Given this list of marker genes CACHD1, ACVR1C, SCEL, GNPAT, SMIM20, FAM20B, PLGLB2, ZNF138, PPP4R2 (NCBI Gene Id 56340), CPOX, PPM1E, TRAPPC10, CHURC1, DIO1, POGK, PLPPR1, PRKAR2B, TRDMT1, HAO1, CDR2, FOXP2, BIN1, NBR1, MACROH2A1, PLGLB1, ATP8A1, ELL2, RBL2, PCDH7, KLRC2, SMAD5, IL17RD, SLC10A2, PA2G4, C5orf24, PDS5B, POU2F1, SESN3, SFSWAP, SRSF2, VAPB, OXR1, SEMA5A, PUM2, ZDHHC20, RAB8B, MYCN, TNKS, N4BP2, PCDH17, LIPA, VCAN, PGAP1, STXBP5, RIF1, CAMTA1, QKI, SHTN1, RNF138, IFNG, SREK1, VAMP4, SRSF10, PALM2AKAP2, IPO7, MYCBP2, AAK1, LACC1, ZNRF3, TBC1D4, KCNQ5, UBE4A, HERC4, KIAA1549L, ZIC5, SLC38A2, DNAJB9, EPHA2, SAMD12, PICALM, RBMS3, RC3H1, KCNMA1, ZNF652, SPCS3, HOXC4, NCOA5, RIMKLB, VGLL3, GAPT, SDC2, STON2, ZSCAN16, IMPG1, NIPA2, OTUD6B, ST13, ATXN3, RAB40B, POGZ, USP10, MAGI3, AKT3, COL8A1, NAP1L3, PRDM10, ALG1 (NCBI Gene Id 56052), NFASC, CNIH1, HMBOX1, MCTP2, FAXC, PANK1, PSMC2, CCNC, LSM8, NDST3, GPR34, CTLA4, PRC1, LPCAT2, ERBB4 (NCBI Gene Id 2066), TM4SF18, MYCT1, MACROH2A2, SCNN1G, MMP8, GALNT13, UBE2K, NPY1R, CTNNA3, SMAD6, B3GNT5, FBXO48 (F-box protein 48), LPL, PCDH10, ARK2N, KLF12, ANKRD44, NKAIN3, PDCD6IP, ZFAND6, KIF5B, PHIP, BRD1, HOXA13, ICE2, OGFRL1, SS18, SGCD, STK17A, FFAR4, RAB4A, LRRFIP1, TFB1M, ZNF512, ZEB2, NECTIN3, YAF2, DYNLT5, KRT6C, SQLE, EBAG9, SSMEM1, YWHAQ, SMCHD1, CLOCK, MFAP3L, NR3C1, ZC3H6, ADAMTS6, RAB11FIP4, BMP2K, FUBP1, SGMS1, CALM1, PAN3 (poly(A) specific ribonuclease subunit PAN3), CPEB3, CYP7B1, LBH (LBH regulator of WNT signaling pathway), ZNF704 (NCBI Gene Id 84737), FEM1B, ESM1, PTBP3, RMND5A, PAPOLG, SLC18A2, TFRC, L2HGDH, LPGAT1, ZBTB41, CCDC186, PKIA, IRS1, PERP, CHIC1, CNOT4, HTR7 (NCBI Gene Id 3363), NIPA1, GUCY1A2, AGPAT5, PTPRB, VIT, DICER1, TOR1AIP2, YBX3, RFTN1, IPPK, A1CF, GREM2, DENND1B, RCAN2, TMF1, TOM1L1, MAGEB3, ITK, ING2, G2E3, TMEM135 (transmembrane protein 135), CCDC82, MOB1B (NCBI Gene Id 92597), TRIP11, SLITRK2, RHOQ, MOB1A, EVA1A (eva-1 homolog A, regulator of programmed cell death), PTPN4, NKX2-1, ACSL6, AMBRA1, GRIN2A, RNASE4, EBF2, UBA6, CAB39, ISCA1, TIA1, CNGB1, SNTB2, CDK2 (cyclin dependent kinase 2), LIN9, GABRA4, SRD5A3, GXYLT1, CHPF2 (chondroitin polymerizing factor 2), CLHC1, SLC16A7, TTC7B, MFSD4B, ELAPOR2, INSIG1, PAFAH1B1, EEIG2, MYRIP, ABCE1, RPAP2, DAAM1, DGKE, CABLES1, PDIK1L, ONECUT2, RPGRIP1L, NDUFS1, RAB27B, ATG14, SORCS3, BMPR2, RBM11, RAPH1, ERICH1, TFDP2, CLEC2A, TRPS1, DSTN, HOOK3, SLC4A4, TGFBR1, DCUN1D4, PLG, TMEM229A (NCBI Gene Id 730975), ADSS1, SKIL, ZNF75D, MLLT3, KNDC1, CCDC47, BTBD10, ENOPH1, GNAI1, PDS5A, SCARA3, PKDCC, OMA1, GNG2, JADE3, AQP11, ATP1B4, IQGAP2, EIF4B, PHF23, PRSS8, SIX4, C8orf34 (chromosome 8 open reading frame 34), LRATD1, IKZF2, CDC14A, ZNF597, RRN3, ANKRD46, PDE1A, CREB1, GPCPD1 (NCBI Gene Id 56261), PNISR, PRDM1, SPOPL, CLDN16, TEAD1, PTGFR, FUCA1, FGD6, FANCF, EML4, KCNQ3, HEATR1, NTRK2, UBR7, ZMAT1, ZNF81, EFEMP1, SLC12A2, WARS2, SOX6, GABPA (GA binding protein transcription factor subunit alpha), ADRA1A, ZNF274, DIAPH3, ZBTB33, SLC5A12, SSR1, AMD1, HNRNPR, ZKSCAN1, RBPMS2, CHD9, FUT9 (fucosyltransferase 9), ZDHHC21, OSBPL8, IGF1, RPS6KB1, IPP, CACNB4, TMOD2, SAXO1, SRSF12, DNAJC27 (NCBI Gene Id 51277), LIMS1, TLCD4, LMO4, SLC1A3, ATG2B, SLC35F5, OSGIN2, TRMT12, BOD1L2, RLIM, TMEM106B, LARP4B, ATL3, RAB33B, USP14, SYT4, AMZ1, GUCY1A1, FRMPD4, MMAA, BMP7, PDE12, GEMIN8, RIOK3, NEUROG1, CLDN8, THAP2, ARL3 (NCBI Gene Id 403), ZNF326, FRK, TBL2, PCMTD1, CCN4, TRMT5, CDK6, ARHGAP29, SPATA6, NCAM1 (neural cell adhesion molecule 1), KCNA4, SNX2, TNPO1 (NCBI Gene Id 3842), RPAP3, SAXO2, FAM117B, CISD2, LGALSL, TRIM2, GRAMD1C, TMEM33, LNPK, ZBTB39, C1orf43, SLC6A4, PIK3R4, BICC1, AKAP12, UBE2W, GPM6B, CREM, EXOC5, ARMC3 (NCBI Gene Id 219681), PRKCB, LARP4, FKBP1A, PSD3, RAB11A, RAB11FIP2, TASOR, MYOZ1, ZMAT3, APBB2, ARF4, TBCA, ATOSA, FAM171B, FAT3 (NCBI Gene Id 440062), SGIP1, ARID4B, CST8, LAMTOR3, PTPN21, BRDT, TENM4, PPP1R9A, MAP3K2, CENPC, CNTN4, TMTC4, DNAJA4, CSRNP3, PRKAB2, ARFGEF2, CNOT6, RSBN1, PRH2, COBLL1, C21orf91, GPATCH2L, CLTC (clathrin heavy chain), TMEM158, RERE, KIAA0040, CA5B, EFNA5, SCAI, CDCP1, CALD1, PHLDA1, MBNL3, CAST, KPNA4, HDAC9 (histone deacetylase 9), ADGRG6, FAM120A, ATP6V1B2, MCFD2, ATE1, MAB21L3, ARHGAP11A, NUS1, PLCXD3, ZNRF2, TRHR (NCBI Gene Id 7201), DOK6, PELATON, AMER2, CHMP2B, NAV2, ALDH1A2, IGF2BP3, AKAP11, KRT6A, SGPP1, NEXMIF, DCUN1D5, PGM2L1, RBM19, ARL4A, ZNF518B, LRATD2, FLACC1, MEOX1, OR11A1, RBBP8, TMTC1 (NCBI Gene Id 83857), KLHL15, BCAT1, SLC36A4, TBP, here is a description of the gene set: Human Gene Set: MIR1250_3P Genes predicted to be targets of miRBase v22 microRNA hsa-miR-1250-3p in miRDB v6.0 with MirTarget v4 prediction scores > 80 (high confidence targets). studied in species Homo sapiens from publication Chen Y, Wang X (PMID 31504780)